The following is a description of a gene set: Human Gene Set: GOMF_NEUROTROPHIN_BINDING species: Homo sapiens Binding to a neurotrophin, any of a family of growth factors that prevent apoptosis in neurons and promote nerve growth., and this is the list of marker genes: FURIN, NTRK3, NGFR, NTRK1, SORT1, NTRK2, PCSK6, HAP1, FSTL4